Given this list of marker genes HOXD4, H2BC1, POLR2H, EGR2, RBBP4, KMT2C, POLR2K, POLR2A, H2BC21, RBBP7, H2BC17, EP300, POLR2E, EZH2, SUZ12, POLR2L, POLR2J, HOXB4, DPY30, NCOR1, H3C1, H2BC3 (H2B clustered histone 3), H2BC26, H2AC6, H2BC9, AJUBA, H2AJ, PAX6, NCOA6 (nuclear receptor coactivator 6), PKNOX1, POLR2F, YY1, H2AC4, H3C15, PIAS2, PBX1, KDM6A, HOXB1, H4C1, MEIS1, POLR2C, H2AC7, PAXIP1, H2AC18, H2BC11, H2BC5, HOXA4, RXRA, NCOA3, RARB, ASH2L, ZNF335, H2AZ2, HOXC4, HOXA3, CNOT6, H2BC13, POLR2D, H2BC12, H2BC4, PCGF2, JUN, POLR2G, CTCF, HOXA2, HDAC3, H3-3A, WDR5, KMT2D, RARA, H2AX, H2BC14, EED, CREBBP, PAGR1, POLR2B, H2BC12L, H2AC14 (H2A clustered histone 14), HOXA1, MAFB, CNOT9, HOXD3, H2AB1, RBBP5 (RB binding protein 5, histone lysine methyltransferase complex subunit), HOXB2, H2BC15, RARG, POLR2I, H2AC20 (NCBI Gene Id 8338), HOXD1, HOXB3, here is a description of the gene set: Reactome Pathway: Activation of anterior HOX genes in hindbrain development during early embryogenesis studied in species Homo sapiens In mammals, anterior Hox genes may be defined as paralog groups 1 to 4, which are involved in development of the hindbrain through sequential expression in the rhombomeres, transient segments of the neural tube that form during development of the hindbrain. Hox gene activation during mammalian development has been most thoroughly studied in mouse embryos and the results have been extended to human development by in vitro experiments with human embryonal carcinoma cells and human embryonic stem cells.<br>Expression of a typical anterior Hox gene has an anterior boundary located at the junction between two rhombomeres and continues caudally to regulate segmentation and segmental fate in ectoderm, mesoderm, and endoderm. Anterior boundaries of expression of successive Hox paralog groups are generally separated from each other by 2 rhombomeres. For example, HOXB2 is expressed in rhombomere 3 (r3) and caudally while HOXB3 is expressed in r5 and caudally. Exceptions exist, however, as HOXA1, HOXA2, and HOXB1 do not follow the rule and HOXD1 and HOXC4 are not expressed in rhombomeres. Hox genes within a Hox cluster are expressed colinearly: the gene at the 3' end of the cluster is expressed earliest, and hence most anteriorly, then genes 5' are activated sequentially in the same order as they occur in the cluster. <br>Activation of expression occurs epigenetically by loss of polycomb repressive complexes and change of bivalent chromatin to active chromatin through, in part, the actions of trithorax family proteins. Hox gene expression initiates in the posterior primitive streak that will contribute to extraembryonic mesoderm. Expression then extends anteriorly into the cells that will become the embryo, where expression is first observed in presumptive lateral plate mesoderm and is transmitted to both paraxial mesoderm and neurectoderm formed by gastrulation along the primitive streak.<br>Prior to establishment of the rhombomeres, expression of HOXA1 and HOXB1 is initiated near the future site of r3 and caudally by a gradient of retinoic acid (RA). (Mechanisms of retinoic acid signaling are reviewed in Cunningham and Duester 2015.) The RA is generated by the ALDH1A2 (RALDH2) enzyme located in somites flanking the caudal hindbrain and degraded by CYP26 enzymes expressed initially in anterior neural ectoderm of the early gastrula and then throughout most of the hindbrain. HOXA1 with PBX1,2 and MEIS2 directly activate transcription of ALDH1A2 to maintain retinoic acid synthesis in the somitic mesoderm. Differentiation of embryonal carcinoma cells and embryonic stem cells in response to retinoic acid is used to model the process of differentiation in vitro.<br>HOXA1 appears to set the anterior limit of HOXB1 expression. HOXB1 initiates expression of EGR2 (KROX20) in presumptive r3. EGR2 then activates HOXA2 expression in r3 and r5 while HOXB1, together with PBX1 and MEIS:PKNOX1 (MEIS:PREP), activates expression of HOXA2 in r4 and caudal rhombomeres. AP-2 transcription factors maintain expression of HOXA2 in neural crest cells. HOXB1 also activates expression of HOXB2 in r3 and caudal rhombomeres. EGR2 negatively regulates HOXB1 so that by the time rhombomeres appear, HOXB1 is restricted to r4 and HOXA1 is no longer detectable. EGR2 and MAFB (Kreisler) then activate HOXA3 and HOXB3 in r5 and caudal rhombomeres. Retinoic acid activates HOXA4, HOXB4, and HOXD4 in r7, the final rhombomere. HOX proteins, in turn, activate expression of genes in combination with other factors, notably members of the TALE family of transcription factors (PBX, PREP, and MEIS, reviewed in Schulte and Frank 2014, Rezsohazy et al. 2015). HOX proteins also participate in non-transcriptional interactions. In zebrafish, Xenopus, and chicken factors such as Meis3, Fgf3, Fgf8, and vHNF regulate anterior hox genes, however less is known about the roles of homologous factors in mammals.<br> Mutations in HOXA1 in humans have been observed to cause developmental abnormalities located mostly in the head and neck region. A missense mutation in HOXA2 causes microtia, hearing impairment, and partially cleft palate. A missense mutation in HOXB1 causes a similar phenotype to the Hoxb1 null mutation in mice: bilateral facial palsy, hearing loss, and strabismus (improper alignment of the eyes). part of: Activation of HOX genes during differentiation